Given this list of marker genes CCN6, GNPTAB (N-acetylglucosamine-1-phosphate transferase subunits alpha and beta), POP1, MGAT2, NEPRO, CDH11, LHX3, SLC26A2, here is a description of the gene set: Human Gene Set: HP_THORACOLUMBAR_KYPHOSCOLIOSIS studied in species Homo sapiens Thoracolumbar kyphoscoliosis